Given this list of marker genes VIM, PPIB, SSR4, CCT2, BGN, POLR1C, ZNF496, PRDX3, SERPINB6, NSA2, TUBB, FXR1, NUDT21, RPS28 (ribosomal protein S28), RPL31, PSAT1, RPH3AL, PAICS, PPM1G, GYG1, HSPA8, ATP5F1A, TUBB2A (NCBI Gene Id 92919), AHCY, SLC25A3, CS, NAP1L1, ENTPD3, TOMM20, TUBB4A, HNRNPA1L2, TCP1, NAA10, VDAC1, EIF2S3, UQCRFS1 (NCBI Gene Id 7386), RPL3 (ribosomal protein L3), OLA1, BTF3, NOL3, MRPL30, GAPDHS, EIF3E, SLC25A17, ATP6V1G2, RPL35A, CNIH1, GTPBP6, BRI3BP, EIF3K, ACOT1, NME2, RPS21, PRCP, RPL36, IGBP1, IMPDH2, RPS26, CCT4, BLVRB, AIMP1, TSPAN15, ACBD6, RPL10A, KDELR1 (KDEL endoplasmic reticulum protein retention receptor 1), CRYZ, SLC25A5, RTRAF, BCS1L, here is a description of the gene set: The tuberous sclerosis complex (TSC) proteins TSC1 and TSC2 regulate protein translation by inhibiting the serine/threonine kinase mTORC1 (for mammalian target of rapamycin complex 1). However, how TSC1 and TSC2 control overall protein synthesis and the translation of specific mRNAs in response to different mitogenic and nutritional stimuli is largely unknown. We show here that serum withdrawal inhibits mTORC1 signaling, causes disassembly of translation initiation complexes, and causes mRNA redistribution from polysomes to subpolysomes in wild-type mouse embryo fibroblasts (MEFs). In contrast, these responses are defective in Tsc1(-/-) or Tsc2(-/-) MEFs. Microarray analysis of polysome- and subpolysome-associated mRNAs uncovered specific mRNAs that are translationally regulated by serum, 90% of which are TSC1 and TSC2 dependent. Surprisingly, the mTORC1 inhibitor, rapamycin, abolished mTORC1 activity but only affected approximately 40% of the serum-regulated mRNAs. Serum-dependent signaling through mTORC1 and polysome redistribution of global and individual mRNAs were restored upon re-expression of TSC1 and TSC2. Serum-responsive mRNAs that are sensitive to inhibition by rapamycin are highly enriched for terminal oligopyrimidine and for very short 5' and 3' untranslated regions. These data demonstrate that the TSC1/TSC2 complex regulates protein translation through mainly mTORC1-dependent mechanisms and implicates a discrete profile of deregulated mRNA translation in tuberous sclerosis pathology. Human Gene Set: BILANGES_RAPAMYCIN_SENSITIVE_VIA_TSC1_AND_TSC2 from publication Bilanges B, Argonza-Barrett R, Kolesnichenko M, Skinner C, Nair M, Chen M, Stokoe D (PMID 17562867) Genes translationally repressed by rapamycin (sirolimus) in MEF cells (embryonic fibroblast) lacking either TSC1 or TSC2 but not in the wild type cells. species: Mus musculus